The following is a description of a gene set: from publication Busslinger GA, Weusten BLA, Bogte A, Begthel H, Brosens LAA, Clevers H (PMID 33691112) studied in species Homo sapiens Human Gene Set: BUSSLINGER_GASTRIC_IMMATURE_PIT_CELLS, and this is the list of marker genes: TRNP1, TSPAN1, TPM4, VSIG1, TFF2, SLC7A8, LGALS9C, PLXNB2, ALDH3A2, CTSE (NCBI Gene Id 1510), VSIG2, SH3BGRL3, PFN1, ACTG1, FOXA2, KRT18, GALNT6, S100A6, CSTB (cystatin B), MAPK3 (NCBI Gene Id 5595), TCEAL9, HPGD, ID1, ABCC5, IL1RN, TXN, SLC9A1, GSN, TAGLN2, JPT1 (NCBI Gene Id 51155), MAL2, KRT8, KRT19, ACTN4, AKR1C3, KLF4, UGDH, PTGR1, HSPB1, CEACAM5, RASSF6, CYP2S1, CYP2C18, CYP3A5, ARPC1A, NQO1, SH3BGRL2, RHOA, CCND1, CTNNA1, PERP (p53 apoptosis effector related to PMP22), AKR1B10, S100P, CLIC1, GPX2, RNASE1, FBLIM1, MGST3, AGR2, NET1, SOSTDC1, FXYD3, CALM2, RAB27A, CLDN18, MANF, MUC1, AKR1C1, ABCC3, TSPAN3, ANXA10, CAST, PHGR1, CBR1, ABLIM1, AHNAK, DYNLL1, JUP, REP15, LMNA, CD2AP, KLF3, PLAC8, VILL, SLC44A2, RALA, CAPG, CAPN8, SYTL2, SPTSSB, ACTB, ALDH3A1 (NCBI Gene Id 218, aldehyde dehydrogenase 3 family member A1), GKN1, RBM47, YWHAZ, FAM120A, S100A16, FLNB, TSPAN8, FHL2, TESC, REG4, CD63, LMO7, PRDX1, RAB27B, TACSTD2, MUCL3, S100A14, GKN2, MGLL, S100A11, AKR1C2, COX8A, EFHD2, BLVRB, SLC5A5 (NCBI Gene Id 6528), SPINT2 (serine peptidase inhibitor, Kunitz type 2), CAPN9, LGALS4, FSIP2, IFI27, FOXQ1, ETNK1, SMPD3, SULT1C2, CMBL, PLA2G10 (phospholipase A2 group X), TMEM54, CYSTM1, FCGBP, ZBTB7C, IL1R2, FA2H, LGALS3, GALE, DSC2, CAPN5 (NCBI Gene Id 7445), TPM1, TENT5A, CRIP1, RAC1, SFN, KDELR2, CFL1, DDX60, CA2, VAMP8, TST, ANG, TMSB4X, LINC01133, TFF1, SPINK1, SLC44A1, ABHD2, TCF7L2, ALDH2, GSTP1, BCAS1, EFNB2, CLTB (clathrin light chain B), CES2, PSCA, ITGB4